The following is a description of a gene set: Human Natural Killer (NK) cells comprise two main subsets, CD56bright and CD56dim cells, that differ in function, phenotype and tissue localization. To further dissect the heterogeneity of CD56dim cells, we have performed transcriptome analysis and functional ex vivo characterization of human NK cell subsets according to the expression of markers related to differentiation, migration or competence. Here, we show for the first time that the ability to respond to cytokines or to activating receptors is mutually exclusive in almost all NK cells with the exception of CD56dim CD62L+ cells. Indeed, only these cells combine the ability to produce interferon (IFN)-gamma after cytokines and proliferate in vivo during viral infection with the capacity to kill and produce cytokines upon engagement of activating receptors. Therefore, CD56dim CD62L+ cells represent a unique subset of polyfunctional NK cells. Ex vivo analysis of their function, phenotype, telomere length, frequencies during ageing as well as transfer experiments of NK cell subsets into immunodeficient mice suggest that CD56dim CD62L+ cells represent an intermediate stage of NK cell maturation, which after restimulation can accomplish multiple tasks and further develop into terminally differentiated effectors. Human Gene Set: GSE21774_CD62L_POS_CD56_BRIGHT_VS_CD62L_NEG_CD56_DIM_NK_CELL_DN species: Homo sapiens Genes down-regulated in NCAM1+ SELL bright versus NCAM1- SELL dim. from publication Juelke K, Killig M, Luetke-Eversloh M, Parente E, Gruen J, Morandi B, Ferlazzo G, Thiel A, Schmitt-Knosalla I, Romagnani C (PMID 20505160), and this is the list of marker genes: IFT70A, GDI1, CREBRF, MTURN, SFR1, IFI44, GTDC1, UBQLN2, ZFPM1, EHBP1, TFDP2, GATA2, USP15, ITGA6, RGS1, SPPL3, TBXAS1, RNF20, GPAM, PLXDC2, ITSN1, PLPP3, E2F6, NDRG3, RBM6, NBEA, CCDC66, CYRIA, IL17RA, DIPK2A, LRRCC1, ST7, NAP1L3, CDKN2D, EPB41 (NCBI Gene Id 2035), PPP1R12A, UPP1, SPTA1, PFKFB2, MYCN, IFIT1B, ATP8A1, PPM1L, PABPC4L, GIMAP5, TRPC6 (transient receptor potential cation channel subfamily C member 6), P2RX1, TMCO6, DIP2C, ESAM, TRIM68, PSD3 (pleckstrin and Sec7 domain containing 3), ZNF740, ITIH5, FBXO9, PITPNC1, HGF, RBPMS2, RAB37, HLF, ITGB3, ZNF287, ST3GAL5, TAF9B, ABCA5, TSPO2, MINDY2, PRELID2, AGO1, ZFAND6, MDC1, CBFA2T2, RGP1, RPS6KA6, MED12L, LPIN1, LSM14A, DCAF12L1, CADPS2, HACD4, GAB1, ATP8B2, BIRC2, PGR, ZNF397, PGAP4, GARRE1, TTC39B, BRDT, ZNF12, HSPA12B, FBXL17, TNIK, FSTL1, MAMDC2, PTGS1, ASB4, IL1RAPL1, FADS2, FOXO3, ZNF841, AFDN, CHEK2, PDZK1IP1, EXOC6, GCH1, GFOD2, C3orf70, KLHDC1, PTPN14, SIK3, PAN2, MFHAS1, TSC22D1, BPGM, CCDC88A, PHC1, TSC1, TMEM40, TSPAN14, CDK17, MYOM1, TGFBR3, SLC38A5, IMMP2L, NUFIP2, CYP4V2, CASD1, CLDN10, HACE1, CSNK1G3, ZNF354A, MEG3, PER3, ARHGAP29, FAM184A, AKAP9, RBM33, CRLF3 (cytokine receptor like factor 3), NEURL1B, PARD6G, MED19, NLK, CSGALNACT1, CELF5, MARVELD2, HECTD4, EPB41L5, GRAMD1C, NSD3, HYCC1, MLLT3, TJP1, GIMAP1, UTRN, DSG2, WDFY3, HSH2D, PLSCR4, WWC2, SLC18B1, MAN2A2, PRDM16, SAMD9L, CISD1, IGIP, RAB40B, TNFSF9, ZMYM5, FNBP1L, NFIA, POFUT1, NDN, MARCHF3, CSAD, CD38, C9orf72, TUT7, USP25, IRF6, SOX6, ENTPD1, GSTM1, CHD6, CA2 (NCBI Gene Id 760), MPL, S100PBP, MADD, SESN3, FAM120C, CLDN7, GIMAP8, ZBTB6, PEAR1, DIAPH1, STX17, CCDC136, CFAP300, MECOM, FHL1